The following is a description of a gene set: Genes up-regulated in dendritic cells: untreated versus 2,4-dinitrofluorobenzene (DNFB). Human Gene Set: GSE20727_CTRL_VS_DNFB_ALLERGEN_TREATED_DC_UP Identification of ROS induced genes on dendritic cells Dendritic cells were incubated for 15 min with or without a ROS inhibitor (DPI), washed extensively and incubated for 30 min with a chemical allergen (DNFB), hydrogen peroxide, and vehicle alone in HBSS containing DPI or vehicle. After washed extensively, the samples were post-incubated for 5.5 h with DNFB, hydrogen peroxide, or vehicle in complete culture medium containing DPI or vehicle. studied in species Homo sapiens from publication Miyazawa M, Takashima A (PMID 22974541), and this is the list of marker genes: OSTC, PCDHGC4, PDIK1L, ITPK1, CARHSP1, ABCB9, PIWIL2, MAFG, CX3CR1, EFHD2, GFPT1, TMEM120A, FCER1G, CBX5, CPTP, NGLY1, VDAC3, ADPRH, NINJ2, NEIL3, CYB561, TMEM106A, LSP1, ERN1, PAXIP1, PLD2, HSF4 (heat shock transcription factor 4), OIP5, PTPN12, CCL4, MUC1, NMRAL1 (NCBI Gene Id 57407), PMCH, GUSB, CREB3L1 (cAMP responsive element binding protein 3 like 1), SEC24D, GSR, FAM81A, DAPK2, LSM2, RDH11, ACOT9, NFIL3, ZBTB42, NCALD, FAAP24, IL1R1, G6PD, CCDC92, RABIF, COX6B1, MELK, NUP93, SH3RF1, UXT, COQ3, DHRS1, HMCES (NCBI Gene Id 56941), CYP11A1, ACTN4, SPAG5, ERBB3, FGR, BRIP1, TG, RAB5IF, SPC24, FAH, PFN1, FDXR, DEF6, ATP1A2 (ATPase Na+/K+ transporting subunit alpha 2), GP5, NELFE (NCBI Gene Id 7936), APOO, TNNI3, PDCD6IP, CD80, NUS1, SERPINI1, CA13, LSS, IRF4, PIH1D1, CTSB, SUN1, PPP1R18, FAXC, ZCCHC3, PRDX2, B4GALT5, ARPC1B, RNF216, KIAA1191, MDGA2, LRP8, SH2D3C, ZFP91, MND1, GNA15, HSD11B1, FAM20A, POLR2K, TMOD3, NSMCE2, RNH1, C11orf16, ARID3A, GHDC, POLD3, NUP37, ADAM8, NFATC1, ATP8B2, TNFRSF21, TNFSF9, IL2RA, DOLK, BAIAP3, GINS2, AMMECR1, SNX9, ESM1, UBXN8, ZIK1, MRPL18, CPD, LIN37, DNA2, TXNDC9, DUSP14, ABR, CPT2, FAM177A1, XK, AIFM1, TATDN1, CENPN, C15orf40, NUBP2, SF3B5 (NCBI Gene Id 83443), GARS1, MSRB1, DZANK1, ST14, DDT (NCBI Gene Id 91323), HAUS3, CRMP1, BTG3, GNA11, SLC9B2, PDCD1, TUBB3, NUDT15, RBM44, TMEM62, FAM72A, SLC66A3, PPIA, SEPTIN10, SPATS2, ACSBG1, UBE2V1, MARK1, PAK6, DCP1B, CENPS, SSR1 (NCBI Gene Id 6745), S100A5, POGK, UQCRFS1, NDUFA4, GAS2L1, PRKX (protein kinase cAMP-dependent X-linked catalytic subunit), MAD1L1, LMAN2, CERCAM, H2AX, LDHA, ZFP41, E2F3, TCF19, DHRS7, IRAK1BP1, TUBE1, GLMP, TENT2 (terminal nucleotidyltransferase 2), XRCC6, ARSB, PMVK, SNRPC, GEMIN2, OSBPL9, CARNMT1, TTC39C (tetratricopeptide repeat domain 39C), ZNF697, GALNT14, FURIN, RFC5, NUDT7